The following is a description of a gene set: from publication Gaucher D, Therrien R, Kettaf N, Angermann BR, Boucher G, Filali-Mouhim A, Moser JM, Mehta RS, Drake DR 3rd, Castro E, Akondy R, Rinfret A, Yassine-Diab B, Said EA, Chouikh Y, Cameron MJ, Clum R, Kelvin D, Somogyi R, Greller LD, Balderas RS, Wilkinson P, Pantaleo G, Tartaglia J, Haddad EK, Sékaly RP (PMID 19047440) Correlates of immune-mediated protection to most viral and cancer vaccines are still unknown. This impedes the development of novel vaccines to incurable diseases such as HIV and cancer. In this study, we have used functional genomics and polychromatic flow cytometry to define the signature of the immune response to the yellow fever (YF) vaccine 17D (YF17D) in a cohort of 40 volunteers followed for up to 1 yr after vaccination. We show that immunization with YF17D leads to an integrated immune response that includes several effector arms of innate immunity, including complement, the inflammasome, and interferons, as well as adaptive immunity as shown by an early T cell response followed by a brisk and variable B cell response. Development of these responses is preceded, as demonstrated in three independent vaccination trials and in a novel in vitro system of primary immune responses (modular immune in vitro construct system), by the coordinated up-regulation of transcripts for specific transcription factors, including STAT1, IRF7, and ETS2, which are upstream of the different effector arms of the immune response. These results clearly show that the immune response to a strong vaccine is preceded by coordinated induction of master transcription factors that lead to the development of a broad, polyfunctional, and persistent immune response that integrates all effector cells of the immune system. Genes down-regulated in peripheral blood mononuclear cell 10d vs 0d in unknown after exposure to YF-Vax/Stamaril, time point 10D Human Gene Set: GAUCHER_PBMC_YF_VAX_STAMARIL_UNKNOWN_AGE_10DY_DN species: Homo sapiens, and this is the list of marker genes: PACS1, SELENBP1, PI3, ALPL, PPM1F, IMPA2, SNRPG, PCBP2, NIBAN1, PINK1, EEF2 (NCBI Gene Id 408221), RPS4X, GLS, SORL1, RUBCNL, RPL37A, TSPAN5, ELAPOR1, EIF4B, MEF2D, DCAF12, TBL1X, CDK19, NPL, PABPC1, LGALS3, STAT5B, OSBP2, LST1, HECA, USP10, PHOSPHO1, ICAM3, GNG7, MYADM, GUCD1, FBXO7, TXNDC12, FOXO1, MPZL1, RFLNB, UBE2H, ORM1, SNCA, EIF3F, PYGL, CYP27A1, TMX4, PITHD1, PDZK1IP1, DDX3X, FCER1A (Fc epsilon receptor Ia), ERGIC1, LINC00265, ABTB1, ADGRE3, FAXDC2, TBC1D14, BTF3, TP53INP2, MKRN1, STMN3, IL1R2, DCAF6 (DDB1 and CUL4 associated factor 6), GPR162, EIF3L, VNN2, PANX2, PIP4K2A, PLVAP, RPS3, WLS (Wnt ligand secretion mediator), TNS1, SIGLEC10, IRS2, TMCO3, PABPC4, EPB42 (NCBI Gene Id 2038), ARAP3, FAM210B, TOPORS, ZNF217, TGM3, SERF2, CPPED1, SRRD, APMAP, ARHGAP24, ABCC5, H1-2, CD46, ALKBH7, KBTBD7, PRDX2, RPS6KA5 (NCBI Gene Id 9252), MPP1, PTOV1, CAMK1D, PRKDC, ABHD5, LMBRD1, RPL22, TAGLN2, HSD17B11, CA4, MED25